The following is a description of a gene set: Down-regulated 'cooperation response genes': responded synergystically to the combination of mutant TP53 and HRAS in YAMC cells (colon). Understanding the molecular underpinnings of cancer is of critical importance to the development of targeted intervention strategies. Identification of such targets, however, is notoriously difficult and unpredictable. Malignant cell transformation requires the cooperation of a few oncogenic mutations that cause substantial reorganization of many cell features and induce complex changes in gene expression patterns. Genes critical to this multifaceted cellular phenotype have therefore only been identified after signalling pathway analysis or on an ad hoc basis. Our observations that cell transformation by cooperating oncogenic lesions depends on synergistic modulation of downstream signalling circuitry suggest that malignant transformation is a highly cooperative process, involving synergy at multiple levels of regulation, including gene expression. Here we show that a large proportion of genes controlled synergistically by loss-of-function p53 and Ras activation are critical to the malignant state of murine and human colon cells. Notably, 14 out of 24 'cooperation response genes' were found to contribute to tumour formation in gene perturbation experiments. In contrast, only 1 in 14 perturbations of the genes responding in a non-synergistic manner had a similar effect. Synergistic control of gene expression by oncogenic mutations thus emerges as an underlying key to malignancy, and provides an attractive rationale for identifying intervention targets in gene networks downstream of oncogenic gain- and loss-of-function mutations. studied in species Mus musculus from publication McMurray HR, Sampson ER, Compitello G, Kinsey C, Newman L, Smith B, Chen SR, Klebanov L, Salzman P, Yakovlev A, Land H (PMID 18500333) Human Gene Set: MCMURRAY_TP53_HRAS_COOPERATION_RESPONSE_DN, and this is the list of marker genes: COL9A3, SBSN, DUSP15, MMP15, BBS7, ABCA1, MTUS1, RASL11A, GARNL3, CPZ, DFFB, SLC27A3, SFRP2, ARHGAP24, ABAT, HEY2, PLXDC2, TNFRSF18, CD55, PERP, PMAIP1, RAI2, SBK1, JAG2, NBEA, PARD6G, FGF18, ID4, BEX1, ID2, PITX2, SCN3B, ESPN, CKMT1B, FHOD3, GCA, NOTCH3, RPRM, MPZL2, DAPK1, PLTP, MAN2B1, DGKA, PRKD1, SATB1, HOXC13, RAB40B, IGFBP2, MS4A10, UNC45B, ELAVL2, ZNF385A, STMN4, NECTIN4, SEMA3D, DIXDC1, TEX15, LDHB, PRKG1, MCAM, EPHB2, MPP7, RB1, CERS4, WNT9A, FAS, ATP8A1